The following is a description of a gene set: A protein ubiquitination process in which a polymer of ubiquitin, formed by linkages between lysine residues at position 6 of the ubiquitin monomers, is added to a protein. K6-linked ubiquitination is involved in DNA repair. Human Gene Set: GOBP_PROTEIN_K6_LINKED_UBIQUITINATION studied in species Homo sapiens, and this is the list of marker genes: UBE2S, WDR24, UBE2D3, RNF144A, RNF4, RNF14, UBE2D4, BRCA1, PRKN, RNF25, UBE2T, BARD1, TRIM21, UBE2J2, RNF6, RNF8